Given this list of marker genes MYMK, VPS13B, B9D2, RPGRIP1, ROR2, EDN1, TBX15, NEK1, TMEM237, PRRX1, MKS1, TMEM231, CEP290, CC2D2A, RBBP8, TMEM67 (transmembrane protein 67), TCTN1, TMEM216, TCTN3, CSPP1, REV3L, PTDSS1, BMP4, OTX2, MYMX, TMEM107, PLXND1, TXNDC15, LMNB2, ECM1, TRIM37, TCTN2, DHCR7, B9D1, RPGRIP1L, GNAI3, GLI3, SMO, PLCB4, here is a description of the gene set: species: Homo sapiens Human Gene Set: HP_APLASIA_HYPOPLASIA_OF_THE_TONGUE Absence or underdevelopment of the tongue. Aplasia/Hypoplasia of the tongue